Given this list of marker genes Clasp2, Clasp1, Plec, Dmd, Agrn, Agr3, Map2, Vcl, Dag1, Agr2, Fkrp, Large2, here is a description of the gene set: Mouse Gene Set: GOMF_DYSTROGLYCAN_BINDING studied in species Mus musculus Binding to dystroglycan, a glycoprotein found in non-muscle tissues as well as in muscle tissues, often in association with dystrophin. The native dystroglycan cleaved into two non-covalently associated subunits, alpha (N-terminal) and beta (C-terminal).